Given this list of marker genes Slc32a1, Slc6a1 (solute carrier family 6 (neurotransmitter transporter, GABA), member 1), Nherf1, Slc7a14, Slc6a6, Slc6a13, here is a description of the gene set: studied in species Mus musculus The directed movement of gamma-aminobutyric acid (GABA, 4-aminobutyrate) into a cell or organelle. Mouse Gene Set: GOBP_GAMMA_AMINOBUTYRIC_ACID_IMPORT